Given this list of marker genes SLC22A12, CCR6, IRF5, DZIP1L, CAV1, PKHD1, OBSCN, SLC25A20, APRT, MT-CO3, PAX2, LPIN1, RYR1, MT-CO1, CCN2, PBX1, HLA-DRB1, here is a description of the gene set: Human Gene Set: HP_OLIGURIA Oliguria species: Homo sapiens Low output of urine, clinically classified as an output below 300-500ml/day.